The following is a description of a gene set: Kaposi's sarcoma (KS) is the most frequent AIDS-associated malignancy, etiologically linked to the infection with the human herpesvirus 8 (HHV-8/KSHV). This member of the gamma-herpesviridae family encodes 81 open reading frames, several bearing oncogenic potential. A constitutively active virally encoded G protein-coupled receptor (vGPCR) readily induces KS-like lesions when expressed in endothelial cells in vivo, and unmasks the oncogenic potential of other HHV-genes in a paracrine fashion. How vGPCR causes endothelial cell transformation is still not fully understood. Using full-genome microarray analysis we show here that the expression of nuclear factor-kappaB (NF-kappaB)-regulated genes is a prominent feature triggered by vGPCR in cells expressing this viral oncogene and in cells exposed to vGPCR-induced secretions, thus mimicking its paracrine effect. Indeed, vGPCR activates the NF-kappaB pathway potently, and NF-kappaB activation is a hallmark of both human and experimental KS. Of interest, whereas constitutive NF-kappaB signaling is not sufficient to promote endothelial cells transformation, NF-kappaB function is strictly required for vGPCR-induced direct and paracrine neoplasia. Taken together, these results strongly support the role of NF-kappaB regulated genes in KS pathogenesis, thus providing the rationale for the development of novel mechanism-based therapies for this angioproliferative disease. from publication Martin D, Galisteo R, Ji Y, Montaner S, Gutkind JS (PMID 17934524) NF-kB-controlled genes up-regulated in endothelial cells in response to viral GPCR protein. studied in species Mus musculus Human Gene Set: MARTIN_NFKB_TARGETS_UP, and this is the list of marker genes: BICDL1 (BICD family like cargo adaptor 1), FLT1, ABCB1, STEAP4, ZCWPW1, SAA1, MYC, NFKBIZ (NFKB inhibitor zeta), CCL7, SLC29A1, CXCL9, VEGFA, OSMR, OPN4, CCL2, MTRF1, C1S, CA2, INHBB (NCBI Gene Id 3625), IGFBP7, CP, GTF3C1, TRIM2, TTYH3, SPP1, IL10, SYN3, TRPV6, C3, VCAM1, PRKCE, PPP1R1B, CASP4, FSD1, BCL2, DUSP6, SLC26A9, SLC16A4, CDC14B, LATS2, CXCL12, PLD4, ATP8A2